The following is a description of a gene set: An ionotropic glutamate receptor activity that exhibits fast gating by glutamate, acts by opening a cation channel permeable to sodium and potassium, and for which kainate is an agonist. Mouse Gene Set: GOMF_KAINATE_SELECTIVE_GLUTAMATE_RECEPTOR_ACTIVITY studied in species Mus musculus, and this is the list of marker genes: Grik2, Grik5, Grik4, Grik3, Gria2, Grik1